The following is a description of a gene set: Reactome Pathway: Synthesis of 5-eicosatetraenoic acids part of: Arachidonate metabolism electronically inferred by orthology from the curated human pathway species: Mus musculus This event has been computationally inferred from an event that has been demonstrated in another species.<p>The inference is based on the homology mapping from PANTHER. Briefly, reactions for which all involved PhysicalEntities (in input, output and catalyst) have a mapped orthologue/paralogue (for complexes at least 75% of components must have a mapping) are inferred to the other species., and this is the list of marker genes: Alox5ap, Ltc4s (NCBI Gene Id 17001), Pon1, Pon3